The following is a description of a gene set: Myeloid differentiation primary response (MyD88) is an adaptor protein that mediates intracellular signaling pathways evoked by all Toll-like receptors (TLRs) except for TLR3 and by several interleukin-1 receptors (IL-1Rs) (Medzhitov R et al. 1998). Upon ligand binding, TLRs hetero- or homodimerize and recruit MyD88 through their respective TIR domains. Then, MyD88 oligomerizes via its death domain (DD) and TIR domain and interacts with the interleukin-1 receptor-associated kinases (IRAKs) to form the Myddosome complex (MyD88:IRAK4:IRAK1/2) (Motshwene PG et al. 2009; Lin SC et al. 2010). The Myddosome complex transmits the signal leading to activation of transcription factors such as nuclear factor-kappaB (NFkB) and activator protein 1 (AP1).<p>Studies have identified patients with autosomal recessive (AR) form of MyD88 deficiency caused by homozygous or compound heterozygous mutations in MYD88 gene leading to abolished protein production (von Bernuth et al. 2008). AR MyD88 deficiency is a type of a primary immunodeficiency characterized by greater susceptibility to pyogenic bacteria (such as Streptococcus pneumoniae, Staphylococcus aureus or Pseudomonas aeruginosa) manifested in infancy and early childhood. Patients with MyD88 deficiency show delayed or weak signs of inflammation (Picard C et al. 2010; Picard C et al. 2011).<p>Functional assessment of MyD88 deficiency revealed that cytokine responses were impaired in patient-derived blood cells upon stimulation with the agonists of TLR2 and TLR4 (PAM2CSK4 and LPS respectively), although some were produced in response to LPS. (von Bernuth et al. 2008). NFkB luciferase reporter gene assays using human embryonic kidney 293 (HEK293T) cells showed that MyD88 variants, S34Y, E52del, E53X, L93P, R98C, and R196C, were compromised in their ability to enhance NFkB activation (Yamamoto T et al. 2014). The molecular basis for the observed functional effects (reported for selected mutations) probably faulty Myddosome formation due to impaired MyD88 oligomerization and/or interaction with IRAK4 (George J et al. 2011; Nagpal K et al. 2011; Yamamoto T et al. 2014).<p>While MyD88-deficiency might be expected to perturb MyD88?IRAK4 dependent TLR7 and TLR8 signaling events associated with the sensing viral infections, patients with MyD88 and IRAK4 deficiencies have so far not been reported to be susceptible to viral infection. part of: Diseases associated with the TLR signaling cascade Reactome Pathway: MyD88 deficiency (TLR2/4) studied in species Homo sapiens, and this is the list of marker genes: TLR2, CD14, porB, S100A9 (S100 calcium binding protein A9), S100A1, S100A8, TLR6, FGB, MYD88, LY96, mip, TLR4, TIRAP, CD36, FGG, BTK, HMGB1, FGA, TLR1